Given this list of marker genes ITGA4, APLN, ITGB1, ITGA9, DOCK4, STUB1, MMP2, SVEP1, ARHGAP42, DOCK5, LEP, ADM, MTNR1B, BMPR2, here is a description of the gene set: species: Homo sapiens Any process that stops, prevents, or reduces the frequency, rate or extent of vasoconstriction. Human Gene Set: GOBP_NEGATIVE_REGULATION_OF_VASOCONSTRICTION